Given this list of marker genes BARD1, PGR, TAF8, ARL2 (ADP ribosylation factor like GTPase 2), CDK5 (NCBI Gene Id 1020), SUN1 (Sad1 and UNC84 domain containing 1), RANGAP1, CIZ1, FAM76B, SP100, MORC3, PARK7, SYNE1 (spectrin repeat containing nuclear envelope protein 1), HDAC3, SUN2, CHCHD10, TAF3, SKP1, HNRNPU, PML, TOPORS, NR5A1, SUPT7L, BBS4, ARL2BP, TXN, here is a description of the gene set: studied in species Homo sapiens Any process in which a protein is maintained in the nucleus and prevented from moving elsewhere. These include sequestration within the nucleus, protein stabilization to prevent transport elsewhere and the active retrieval of proteins that escape the nucleus. Human Gene Set: GOBP_MAINTENANCE_OF_PROTEIN_LOCATION_IN_NUCLEUS